Given this list of marker genes Itgb7, S100a6, Fcer1g, S100a4, Il18r1, Shisa5, Fxyd5, here is a description of the gene set: from publication Cui A, Huang T, Li S, Ma A, Pérez JL, Sander C, Keskin DB, Wu CJ, Fraenkel E, Hacohen N (PMID 38057668) Mouse Gene Set: CUI_ILC_IL1B_RESPONSE_DN Genes negatively differentially expressed in cell type: ILC (innate lymphoid cell) upon treatment with cytokine: IL-1β in mouse lymph nodes in vivo. studied in species Mus musculus Cytokines mediate cell-cell communication in the immune system and represent important therapeutic targets. A myriad of studies have highlighted their central role in immune function, yet we lack a global view of the cellular responses of each immune cell type to each cytokine. To address this gap, the authors created the Immune Dictionary, a compendium of single-cell transcriptomic profiles of more than 17 immune cell types in response to each of 86 cytokines (>1,400 cytokine-cell type combinations) in mouse lymph nodes in vivo. A cytokine-centric view of the dictionary revealed that most cytokines induce highly cell-type-specific responses. For example, the inflammatory cytokine interleukin-1β induces distinct gene programmes in almost every cell type. A cell-type-centric view of the dictionary identified more than 66 cytokine-driven cellular polarization states across immune cell types, including previously uncharacterized states such as an interleukin-18-induced polyfunctional natural killer cell state.